Given this list of marker genes Cdh8, Hoxa10, Kat6b, Lats2, Celf2, Tubb2b, Or7d10, Khdc1b, E230025N22Rik, Brdt, Cnep1r1, Slc44a5, Tll1, Fam168a, Wnt3, Sucla2, Rlbp1, Plagl1, Vegfa, Bdnf (NCBI Gene Id 12064), Sspn, Cacna1c, Zfp354a, Galnt3, Dio1, Zdhhc6, Pnma2, Epha5, Acbd3, Ccng2, Ubl5b, Gnat1, Parvg, Zfpm2, Mtss1, Vapa, Ilf3, Pik3cg, Vwc2l, Setd7, Api5, Nde1, Map3k15, Chm, Trim39, Dnaaf6rt, Tnks1bp1, Tfrc, Polb, Tmem263, Sult2a8, Ddx50, Cpeb3, Sec22c, Fadd, Fbxw11, Col1a1, Tfap2b, Snap91, C9orf72, Elavl1, Hoxd13, Gadd45a, C2cd2, Ube2w, Cdc42ep4, H1f0, Ankrd12, Cdr2l, Mettl14, Pip4p2, Pcna, Mtr, Dtna, Wwp2, L3mbtl3, Mef2a, Ngly1, Dnaaf6, Med30, Srpx, 1700034J05Rik, H2bc23, Cyp1b1, H2bc24, Tmem108, Snx10, Sowaha, Fzd7, Elavl4, Ube2q1, Adra2c, H2-T3, Mideas, St8sia5, Rab11fip1, Stau1, Sp4, Znrf1, Nsd1, Ubn2, here is a description of the gene set: from publication Chen Y, Wang X (PMID 31504780) Mouse Gene Set: MIR_6994_5P studied in species Mus musculus Genes predicted to be targets of miRBase v22 microRNA mmu_miR_6994_5p in miRDB v6.0 with MirTarget v4 prediction scores > 80 (high confidence targets).